The following is a description of a gene set: from publication Pasqualucci L, Bhagat G, Jankovic M, Compagno M, Smith P, Muramatsu M, Honjo T, Morse HC 3rd, Nussenzweig MC, Dalla-Favera R (PMID 18066064) Most human B cell non-Hodgkin's lymphomas (B-NHLs) derive from germinal centers (GCs), the structure in which B cells undergo somatic hypermutation (SHM) and class switch recombination (CSR) before being selected for high-affinity antibody production. The pathogenesis of B-NHL is associated with distinct genetic lesions, including chromosomal translocations and aberrant SHM, which arise from mistakes occurring during CSR and SHM. A direct link between these DNA remodeling events and GC lymphoma development, however, has not been demonstrated. Here we have crossed three mouse models of B cell lymphoma driven by oncogenes (Myc, Bcl6 and Myc/Bcl6; refs. 5,6) with mice lacking activation-induced cytidine deaminase (AID), the enzyme required for both CSR and SHM. We show that AID deficiency prevents Bcl6-dependent, GC-derived B-NHL, but has no impact on Myc-driven, pre-GC lymphomas. Accordingly, abrogation of AID is associated with the disappearance of CSR- and SHM-mediated structural alterations. These results show that AID is required for GC-derived lymphomagenesis, supporting the notion that errors in AID-mediated antigen-receptor gene modification processes are principal contributors to the pathogenesis of human B-NHL. Genes down-regulated in post-GC, BCL6 dependent B cell non-Hodgkin's lymphoma (B-NHL) vs MYC driven pre-GC lymphoma. studied in species Mus musculus Human Gene Set: PASQUALUCCI_LYMPHOMA_BY_GC_STAGE_DN, and this is the list of marker genes: EMB, NAPSA, PHC2, CORO1A, HHEX, USP25, CCR7, RCSD1, BLVRB, BCL7A, NIBAN3, LSP1, CORO7, TOP2B, SLC25A37, CDKN2C, SMARCE1, FAM43A, DIRAS2, CD24, DEK, RIN3, ACSS1, H2BC11, RASGRP1 (NCBI Gene Id 10125), IGHD, TNFRSF19, SMS, CBFB, ID3 (inhibitor of DNA binding 3), NAP1L1, SERPINB1, S1PR4, LIMD2, CNN3, MTPN, TRIB2, GFOD1, ANKRD13A, MEX3B, SPAST, COTL1, PDE3B, KLHL24, RBM43, SESN3, BRD3, FUS, TNFAIP8, LACTB, BAG2, UQCC5, SASH3, PCLAF, SUSD3, CPLX2, RASGRP2 (RAS guanyl releasing protein 2), MYO1G, ARHGAP15, EZH2, SH3KBP1 (NCBI Gene Id 94010), GMFG, SH3BP5, TMEM243, CYFIP2, PAX5, KLF2, E2F2, WDFY4, CD79A, RBM38, CD19, IRAG2, CLIC1 (chloride intracellular channel 1), BACH2, PRKACB, FRYL, NEDD9, CDKN2D, FCRLA, TMSB10, ZFPM1, GPD1L, UBE2D1, ARHGDIB, NUDT19, SYPL1, PGP, PTGR3, SRSF1, PUM2, RFX7, WAS, FAM111A, ANKRD44, CNOT6L, B3GNT5, FRAT2, CD22, SYNCRIP, BANK1 (NCBI Gene Id 55024), CPM, PPM1E, CELF2, STAG2, VPREB3, CECR2, CAMKK2, BTBD1, CRIP1, PLEKHA2, STK4, CCDC50, MTERF2, UBE2D3, ZCCHC2, FH, RASSF3, CHCHD10, PDLIM1, ETS1, DNAH8, FCHO1, RABEP2, SBK1, PDE2A, ITPR1, CKLF, SNN, CPSF6, JAKMIP1, S100A10, SNRPN, ARHGEF18, CD37, RDH12, CHST7 (NCBI Gene Id 56548), KLHL14, PTBP3, MYBPC2, BCL11A, HNRNPDL, RIPOR2, CHD1, ANP32E, TNNI2, DNAJC9, CD55, MKNK2, BTG1, OBI1, CUX1, ZBTB18 (zinc finger and BTB domain containing 18), CXXC5, CPN1, PTPRCAP, LCP1, EBF1, RNF2, CDK19, STX7 (NCBI Gene Id 8417), BCAT1, TUSC3, TMEM229B, AFF3, GYPC, SNX2, SMIM14, PRKCB, NUCKS1